The following is a description of a gene set: species: Homo sapiens A molecular function characterized by the coupling of ATP hydrolysis to other steps of a reaction mechanism to make the reaction energetically favorable, for example to catalyze a reaction or drive transport against a concentration gradient. Human Gene Set: GOMF_ATP_DEPENDENT_ACTIVITY, and this is the list of marker genes: SMC1A, KIF13B, MYO6, DDX60L, HSPA1B, LONP2, ATP8A1, VCP, DNAH5, MOV10, ATP13A1, KIF5B, ATP6V1G2, ERCC2, MSH3, DDX4, CLPX, EIF4A1, HELB, DYNC1H1, ATP13A4, MYL6, ATP1A4, DDX52, ABCC12, KIF12, RUVBL2, DDX49, GPN1, KIFC2, ATP7B, TNNT2, DNAH17, HSPA14, NLRP10, KATNA1, ABCG8, DDX46, DDX3Y, KIF1B, ERCC3, KIF2C, NAV3, RHOBTB3, KIF13A, ATRX, DDX19B, POLQ, ABCD4, HSPA9, UBA5, ATAD1, SMC3, MCM9, MCM4, KIF28P, MYO9A, GTF2H4, HSPA7, ABCB11 (NCBI Gene Id 8647), ATP12A, KIF7 (kinesin family member 7), MYH14, MCM7, KIF20A, ACSL3, PSMC6, DNAJC24, DDX51, HSPA1A, DHX16, ACSM4 (NCBI Gene Id 341392), CHD1, DDX11L8, CHD4, PSMC1, ATP10A, DNAJB4, TAP2, KIF18B (kinesin family member 18B), DDX18, MYO5C, MLH1, MORC4, APPBP2, FANCM, HSP90AB2P, ATG7, RFC3, SLFN11, ABCG4, DDX28, ABCD3, CCT8L1P, DYNC2H1, ATAD3A, CFTR, XRCC5, ATP4B, TCIRG1, HSPH1, DNAH9, ABCF2, TOR1AIP1, MCM5, DNHD1, DHX38, SMC2, KIF3C, DNAH12, HSPA6, MYH2, CHD3, MYO5B, INO80, COQ8B, KIF18A, SPAST, ACSF3, AK6, KIFC1, CHD9, ATP1B3, WAPL, EP400, HSPA4, ABCD1, ABCC2, ATP6V1C1, ATP8B1, IGHMBP2, AHSA2P, BLM, ABCG1, XRCC6, AFG2A, TOP2A, YTHDC2, MYO10, PFN2, ATAD3C, HSCB, MYH9, ABCC9, ATP9B, DNAJC2, NSF, IDE, ATP2A3, HELZ2, DDX6, RAD54L2, UPF1, ATP6V0B, SHOC1, BAG3, ACSBG1, CHD5, ATP2C1, YME1L1, DNAH7, ATP2A1, KIF5C, IQCA1L, ATP6V0E2, ATF7IP, ATP6V1G1, ABCB4, EIF4A3, ATP6V0A2, DDX21, ATP6V1F, HSP90B2P, SIL1, BAG4, SLC27A1, CCT8, ATP2C2, MCM6, SMARCA5 (SWI/SNF related, matrix associated, actin dependent regulator of chromatin, subfamily a, member 5), ATP6V0A1, KIF5A, RBBP4, ALPL, DDX41 (DEAD-box helicase 41), SKIC2, NKRF, CHTF8, VPS4A, MYH8 (NCBI Gene Id 4626), PMS2P3, ATAD5, DNAH10, KATNAL1, KIF21B, DNAI2, DDX23, TMEM30B, NAV1, ZGRF1, TOR1B, SMC4, DHX33, ACSM2A, HDAC6, OLA1, MYBPC3, ATP8A2, DDX12P, HSP90AB3P, TRAP1, VWA8, MSH6, DDX19A, SMARCAD1, DNAJB1, DDX42, ABCC6, DDX10, ABCA13, ATP6V1A, SLC27A4, DYNLRB2, KIF9, DNAJC7, MYO1B, SMCHD1 (structural maintenance of chromosomes flexible hinge domain containing 1), DDX56, DDX43, SLC27A6, ATP13A5, SLC27A3, ERCC6, GRPEL2, NLRP3, SPG7, ATP5F1B, MORC3, ABCB5, ACSL1, SLC27A5, PMS2P5, GRPEL1, ABCE1 (NCBI Gene Id 6059), HELQ, ACSM5, AHSA1, KIF27 (NCBI Gene Id 55582), CCT3, EIF4A2, MYH3, MYO19, RECQL5, MYO1C, SAE1, TOP2B, ATP6V0E1, MYO7B, ATP8B3, ABCA9, SRCAP, ATP13A2, KIF4A, RFT1, DNAH3, ATP6V1C2, ATP6V1B1, KIF19, ABCB10, KIF16B, DDX24, MYO3A, ATAD2 (NCBI Gene Id 84325), ABCC3, FBH1, FIGN, ATP11A, ATP6V1G3, DNAJC15, DDX1, AFG1L, PMS2P1, ABCC11, CHD8, ENTPD1, CHD1L, STARD9, KIF4B, ABCG5, C10orf88, SMARCA4, ACSM1, CLU, ATP2B1, SPO11, ABCB9, TMEM94, KCNJ11, LONP1, RAD17, ATP6V1H, MCM2 (minichromosome maintenance complex component 2), DQX1, DDX27, DHX15, ATP10D, ACSM3, SNRNP200, CCT6B, ATP9A, CENPE, HFM1 (helicase for meiosis 1), MLH3, ACSM2B, TOMM20, ACSS1, ABCA6 (ATP binding cassette subfamily A member 6), TOR4A, CCAR2, DMC1, ORC1, NAIP, DDX55, ABCB8, HELLS, MOCS3, HSP90AA1, HSP90AA4P, ACSL6 (acyl-CoA synthetase long chain family member 6), HLTF, BAG5, ABCA2, BTAF1, ABCA12, BAG1, MYO1D, MYO1G, ACSL5, DDX11, ABCB1, MSH2 (NCBI Gene Id 8169), DDX3X, ATP6V1E1, MYO5A, ATP2B3, RFC5, DNAH8, MCM3, HELZ, IFIH1, ATP13A3, RUVBL1, MYH1, DHX36, RECQL, PEX1, SRP54, HSP90AA5P, CECR2, TOR1AIP2, WRN, ATP6V0D1, ACSM6, MDN1, KIF14, CCT4, SLC36A1, RFC4, AQR, ABCA7, MSH5, MYH11, ATP4A, G3BP1, CARNS1, CHD6, FNIP2, RSF1, SMC5, HSPA2, ACIN1, ORC4, ATP1A1, DNAH1, AFG3L2, HSP90AA2P, KIF2B (NCBI Gene Id 84643), KIF26A, TOR3A, ATP6AP1, MSH4, RIGI, DDX60, ATAD2B, KIF24, PSMC2, SMARCA1, RFC1 (NCBI Gene Id 5981), DHX34 (NCBI Gene Id 9704), MYH4, ATP10B (NCBI Gene Id 80225), ZRANB3, NUBP2, KIF15, TAP1, ACSS3, SETX, DNAH2 (NCBI Gene Id 57637), ATP5IF1, DNAJC1, ABCD2, SMARCAL1, KIF3B, ATP5PO, BPTF, DNA2, ATP1B2, RAD50, HSPA13, MYH7, BRSK2, ATP5F1A (NCBI Gene Id 502), DHX9, DYNLRB1, PSMC3, DYNC1I2, MYO1E, NUBPL, DNAJA1, TP53, DDX5, MYO9B, NAE1, DNAJC10, SMC1B, DDX39A, XRCC3, ABCC5, ATAD3B, KIF6, TWNK, MYO3B, SMC6, ATP8B2, ABCF1, ATP2B4, IQCA1, MYO18A, DDX47, CHD2, ABCA8, DNAJA2, KIFC3 (kinesin family member C3), ACTB, FIGNL2, SLC27A2, HSP90AB4P, DYNC1I1, TTF2, ATP6V0D2, DDX53, PSMC4, DDX20, SMPDL3A, DDX50, ATP1A3, PFN1, WRNIP1, RALBP1, ATP11C (NCBI Gene Id 57206), MCM8, NLRP1, MYO1H, ABCC4, RAD54B, MYH13, PEX6, RAD51B (RAD51 paralog B), DNAJB6, SWSAP1, DNAH14, TSC1, CCT6A, TRIP13, ATP6V1B2, ABCB7, HSP90B1, UBA6, KIF23, KIF11, MYO1A, ATP8B4, PSMC5, UBA3, ATP2B2, KIF21A, CDC6, DDX31, PMS1, PMS2, MRE11, RECQL4, CLPP, MTREX, ATP6V1D, ACSF2, TDRD9, NTPCR, HSPA1L, KIF2A, DDX25, RTEL1, ABCA10, KIF25, FXYD2, ATP1A2, MYO7A, KATNAL2, DNAL4, ASCC3, HSPA5, ACSL4, ABCF3, HSPA8, RAD51, DDX54, DNAH11, BCS1L, ACSS2, ABCC1 (NCBI Gene Id 8133), DDX59, AFG2B, DNAJC19, ACSBG2, PIF1, SRPRA, SHPRH, DNAH6, RAD51D, PLN, VPS4B, TOR1A, MYO15A, NUBP1, KCNJ8, ACTC1, UBA2, ABCA1, MYH6, ABCG2, ATP11B, UBA1, CCT7, TDRD12, DHX40 (DEAH-box helicase 40), MYH7B, DHX37, ABCA5, KIF22, DHX57, RAD51C, KIF17, ABCA3, KIF20B, ABCA4, CCT5, DDX39B, KIF1C, KIF3A, DHX32, PMS2P6, ATP1B1, DHX8, SUPV3L1 (NCBI Gene Id 6832), CDK7, MYO1F, FIGNL1, ERCC6L2, ZNFX1, CHD7, MYH15, DNAJB2, TCP1, MYH10, DHX35, ATP7A, RNF213, RAD54L, ATP6V1E2 (ATPase H+ transporting V1 subunit E2), CLPB, KATNB1, ABCC10, BRIP1, XRCC2, DHX58, DSCC1, ABCB6, HSP90AB1, MOV10L1, MORC2, DDX17 (NCBI Gene Id 10521), NAV2, KIF26B, DHX29, CCT2 (chaperonin containing TCP1 subunit 2), BAG2, CCT8L2, TMEM30A, ATP2A2, AK9, RFC2, ATP6V0C, ATP6V0A4, ERCC6L, FNIP1, CHTF18, ABCC8, MFSD2A, HSPBP1, UBA7, HSPA4L, HSPD1, HYOU1, MYD88, NVL, DICER1, ATP5F1C, GET3, SMARCA2, DHX30, TOR2A, KIF1A